The following is a description of a gene set: species: Mus musculus Mouse Gene Set: GOBP_NEGATIVE_REGULATION_OF_PROTEOLYSIS_INVOLVED_IN_PROTEIN_CATABOLIC_PROCESS Any process that stops, prevents or reduces the frequency, rate or extent of proteolysis involved in protein catabolic process., and this is the list of marker genes: Uchl5, Psmf1 (NCBI Gene Id 99294), Senp1, Rps7, Styx, Anks1, Svip, Prmt6, Prkcg, Usp25 (ubiquitin specific peptidase 25), Eif3h (NCBI Gene Id 68578), Smarcc1, Epha4, Wnt1, Taf9, N4bp1, Phf20l1, Ddrgk1, Mtm1, Usp38, Rpl23, Ttc36, Clec16a, Usp9x, Sgta, Map1a, Rybp-ps, Ophn1, Alad, F8a, Lamp3, Pabpn1l, Tlk2, Usp14, Pbk, Fhit, Klhl40, Ccar2, Usp7, Styx-ps, Psme3ip1, Hfe, Usp19, Rpl11, Rpl5, Psen2, Trim39, Caml, Ubxn2a, Cdkn2a, Rybp, Park7, Bag5, Hsp90ab1, Usp26, Pdcl3, Gabarapl2, Csnk2a2, Bag6, Psen1, Sco1, Aqp11, Nop53, Ogt, Shh, Csnk2b, Gipc1, Wac, Marchf7, Sufu, Qrich2, Ufsp2, Usp5, Pml, Ubxn1, Hipk2, Efna1